Given this list of marker genes ENTPD1, CAPG, LAT2 (linker for activation of T cells family member 2), CDKN1A, EYA2, TRIB1, DCUN1D3, ISG20, TGFBR3, SPNS3, SRGAP3, MEF2A, TRAF1, ACOT9, TTC39C, GZMB, SSBP2, PLAC8, GPR171, ADAM8, CHRAC1, SV2C, DNAJB14, ST8SIA1, ERN1, RGS16, PYGL, RBPJ, SKAP2, INPP4B, CD101, ULK3, DEGS1, CD96, TCIRG1, GLRX, GPR68, ITGAE, IFITM3, RSU1, FAN1, XKR9, SYTL2, RFTN1, PGGHG, SWAP70, LDAF1, HASPIN, B4GALNT4, NINJ1, EHD1, ADGRG1, ANKRD28, TIGIT, NEK6, TMEM163 (NCBI Gene Id 81615), CDC14A, CD8A, TSPAN3, PAG1, ITGAV, ADRB1, TJP1, EEF2K, DNAI4, ITGA1, PHAX, GNG2, ARHGEF12, PLOD2, INPP5F, HPGDS, ZC3H12C, CISH, SNX9, MTA3, SMYD3, CCDC154, TNFSF10, HSPBAP1, ZNRF1, SEPTIN4, MYO3B, ESM1, EBPL, GRINA, SH3BP2, PRKACB, DDX59, LY6G5B, ATP8A2, ADORA3, DGAT1, RNF149, NVL, TNFSF13B, RUNX2, TNF, LMNB1, WDR13, WBP1, CCR1, ST3GAL4, SLC16A10, JAML, PFN2, TLCD1, ARFGAP3, CD86, METRNL, AMPH, ASNS, CD99L2, OSBPL3 (NCBI Gene Id 26031), SMYD1, HPSE, CPD, SLC41A2, GNAQ, KCNA3, CCR8, CTLA4, TMEM171, SELENOM (selenoprotein M), SOAT2, RNF130, FNDC3A, PAOX, FGL2, CLEC12A, IRAK3, RDH12, GABARAPL1, CD38, MT1A, APAF1, CIB1, ABHD4, MATK, LSP1, MED30, ATP2B4, NFKBIE, KARS1, AHI1, CSGALNACT2, SQLE, DDX55, FOXRED2, IL7R, ARHGAP39 (Rho GTPase activating protein 39), RGS10, IFITM1 (interferon induced transmembrane protein 1), IFITM2, GPR34, SLC20A2, ZYG11B, CRADD, CD3G, NDUFB8, UHRF2, NUCB2, IL2RA, NEDD9, GALNT3, FBXO30, LITAF, NCEH1, CCDC69, SURF4, PON3, HIP1, TMEM59, ACADM, here is a description of the gene set: studied in species Homo sapiens from publication Lind EF, Ahonen CL, Wasiuk A, Kosaka Y, Becher B, Bennett KA, Noelle RJ (PMID 18566401) Genes down-regulated in dendric cells: untreated versus LPS and anti-CD40. Human Gene Set: GSE7219_UNSTIM_VS_LPS_AND_ANTI_CD40_STIM_DC_DN This study aims at identifying genes that are NIK/NF-kappaB2 responsive in murine dendritic cells matured in vivo.